Given this list of marker genes AKAP9, FAM53B, RABGAP1L, NLRC5 (NCBI Gene Id 84166), PRKCA, DECR1, ETNK1, XAF1, KIF13A, FMO5, FAM53A, KDM5B, MTFR1L, ZUP1, TRIM25, GNL3, BANK1, KCNAB1, SYNE1, CRYBA1, IL6ST, VIPR1, TRIM39, MTSS1, PHYH, RFX7, CASD1, TBC1D23, CR2, GPR52, ID3, KCTD19, ZCCHC7, ASH1L, KMT5B, PANK1, FBXL17, RICTOR, ACP5, MGST2, MAP3K5, MYB, WDR37, NUP153, UTRN, EIF2AK4, MARVELD1, S100PBP, BACH2, PLOD2, IL12B, CHD9, DPP4 (dipeptidyl peptidase 4), PLA2G3, CD5, PGPEP1, DDIT4, GPR183, INSYN2B, ALAS2, RIMOC1, ZMYM5, CMYA5, PATJ, REL, NBN, RNF185, RHBDD2, EVL (Enah/Vasp-like), IRF9, NSD1, ATP10D, NEU3, P2RX4, PCMTD2 (NCBI Gene Id 55251), TRAF1, SFMBT2, MBNL2, MDN1, PLEKHG2, ENTPD4, PLEKHA1, LINC-PINT, WAC, CD6, TSPAN13, GRAMD1B, CBLB, ARRB1, EPCAM, BTG1, AKAP13, JMJD1C, STAR, LEF1, SSBP2, RAPGEF4, CD22, FILIP1L, RSF1, IFIH1, FOXP1, NIPBL, LCLAT1, TRIM14, MGAT5, RIMKLA, GBE1, ZFP36L1, OGT (O-linked N-acetylglucosamine (GlcNAc) transferase), TIMP2, ATP8A1, DOCK2, NNT, DYNLT3, ALDH6A1, RPS26, NAP1L5, MYCBP2 (MYC binding protein 2), USP45, ASAP1, PTPN13, ACTN1, ZKSCAN3, PRMT6, TCF7, TULP4, BEX2, PELI1, TOX, INSR, SLC12A7, RPLP2, GPRASP3, TBC1D5, GABBR1, TRAF5, AGL, SPECC1L, FNBP4, PIK3IP1 (phosphoinositide-3-kinase interacting protein 1), RIC8B, AR, ST7, SMG6, ARMCX2, PPIC, P2RX7, NISCH, CDC37L1, DUSP12, TCF12, IKBKE, SIDT1, EIF4G3, SLC28A2, SOCS5 (NCBI Gene Id 9655), WDR49, here is a description of the gene set: from publication Tomayko MM, Anderson SM, Brayton CE, Sadanand S, Steinel NC, Behrens TW, Shlomchik MJ (PMID 18566367) species: Homo sapiens Genes down-regulated in B lymphocytes: naïve versus memory. Memory B cells play essential roles in the maintenance of long-term immunity and may be important in the pathogenesis of autoimmune disease, but how these cells are distinguished from their naïve precursors is poorly understood. To address this, it would be important to understand how gene expression differs between memory and naive B cells in order to elucidate memory-specific functions. Using model systems that help overcome the lack of murine memory-specific markers and the low frequency of antigen-specific memory and naïve cells, we undertook a global comparison of gene expression between memory B cells and their naive precursors. 1st generation screen: These data represent our first generation comparison of gene expression between murine naïve and memory splenic B cells. Naïve NP-binding splenic B cells were FACS purified from unimmunized mVh186.2 transgenic Balb/c mice. Memory B cells were generated by immunizing mVh186.2 transgenic Balb/c mice with 2 doses of NP-CGG in alum delivered i.p. 6 weeks apart. After a minimum of 12-weeks rest, NP-binding splenic B cells were isolated by FACS. Total RNA was extracted, cRNA synthesized and labeled and hybridized to Affymetrix mouse 430 2.0 chips. 2nd generation screen: These data represent our second generation comparison of gene expression between murine naïve and memory splenic B cells. Naïve NP-binding AA4.1neg splenic B cells were FACS purified from unimmunized mVh186.2 transgenic Jk KO Balb/c mice. Memory B cells were generated from these naive precursors after adoptive transfer into recipients that mount poor endogenous NP-responses. 12-weeks post i.p. immunization with NP-CGG in alum, NP-specific splenic memory B cells were isolated by FACS. Total RNA was extracted, cRNA synthesized and labeled and hybridized to Affymetrix mouse 430 2.0 chips. Memory/Naïve comparison data linked below as Supplementary files. Human Gene Set: GSE11386_NAIVE_VS_MEMORY_BCELL_DN